The following is a description of a gene set: The process whose specific outcome is the progression of a trachea over time, from its formation to the mature structure. The trachea is the portion of the airway that attaches to the bronchi as it branches. species: Mus musculus Mouse Gene Set: GOBP_TRACHEA_DEVELOPMENT, and this is the list of marker genes: Rarg, Ctnnb1, Edaradd, Hydin, Mapk3, Lef1, Tgfbr2, Wnt7b, Bmp4, Map2k2, Srf, Shh, Hoxa5 (homeobox A5), Map2k1, Lrp6, Rspo2, Mapk1, Ano1, Sox9 (SRY (sex determining region Y)-box 9), Rara, Eda, Foxf1